The following is a description of a gene set: Mouse Gene Set: GOBP_REGULATION_OF_SYNAPTIC_TRANSMISSION_DOPAMINERGIC Any process that modulates the frequency, rate or extent of dopaminergic synaptic transmission, the process of communication from a neuron to another neuron across a synapse using the neurotransmitter dopamine. species: Mus musculus, and this is the list of marker genes: Flot1, Cntnap4, Chrnb2, Kcnq4, Ptgs2, Arrb2, Chrna7, Pink1, Pmch, Pnkd, Slc6a4